The following is a description of a gene set: Human Gene Set: MIR5001_5P species: Homo sapiens from publication Chen Y, Wang X (PMID 31504780) Genes predicted to be targets of miRBase v22 microRNA hsa-miR-5001-5p in miRDB v6.0 with MirTarget v4 prediction scores > 80 (high confidence targets)., and this is the list of marker genes: SON, PPIE, KIAA0930, NKAIN2, ZNF672, PACS1, MAP6D1, NPTX1, GPRIN1, GAB1, LIFR, TRMT61A, ZBTB4, NKIRAS2, SLC6A17, ZNF395, CTCF, PKLR, PKIG, EIF5, NMD3, YY1AP1, PEX14, SLC2A8, GIPC3, MFAP1, LARP1, NDRG4, JMJD8, KCNS1, STUM, CLDN19, CDR2L, IGFBP5, BPTF, ARRB1, SEMA7A, MPZL2, PDE4D, SH3PXD2B, TRAF7, PAX7, ACE, RAB6B, KLK4, MYO1C, RELT, SYNDIG1L, ZNF219, ENG, TM2D3, MBTD1, TTL, GNAI2, ABCF2, TTYH3, GNG13, STRBP, GLIS2, PMM2 (phosphomannomutase 2), UBA1, AP5B1, CNIH2, TAOK2, GFI1, SHB, KIAA0513, COPS7B, SZT2 (SZT2 subunit of KICSTOR complex), SH3PXD2A, DNAJB5, JPH3, CERS1, SDC3, PKP2, SDK2, LZTS1, SRSF7, APLN, DENND2B, OTOF, MTCL2, KCNIP3, ERC1, WDR48, TAGLN, ACVR1B, IQSEC2 (IQ motif and Sec7 domain ArfGEF 2), CDC42SE1, PHLDB1, SLC45A2, BCAM, RAP1GAP2, GPBP1L1, SEPSECS, PTPRF, TRAF1, APC2, REXO1, NFIC, CLDN18, TTLL6, SYNJ1, FAM219A, CUEDC1, ZNF609, CPEB3, NATD1, CLIP3, BCL2L13, ST3GAL1, PPM1H, PPP3R2, CRTC1, ADGRL1, PARVG, PML, CLDND1, ABCF1, SYT7 (synaptotagmin 7), NCOR1, CLCF1, BTF3L4, LRP1, SPOCK2, TRPM3, ZFR2, CNP, MDGA1, STK40, NECTIN1, FBXO41, SMPD3, OSBP2, HOXA7, ATP2B2, ARL2BP, PPIL2, PRLHR, ARHGAP1 (NCBI Gene Id 392), TBL1XR1, AOC3, EEFSEC, GRIK3, RPL28, NAP1L3, CPLX2, VAMP1, EVC, TMCC3, ACVRL1, NFIX, RAB5A, RNF20, GSK3A, FBXL16, CDYL2, TOX2, LOXL3, ITCH, TYSND1, KIF21B, PLXDC2, CPSF7, RPIA, OLFML2A, WARS1, ARID3B, PPP1R11